The following is a description of a gene set: The chemical reactions and pathways involving isoleucine, (2R*,3R*)-2-amino-3-methylpentanoic acid. Human Gene Set: GOBP_ISOLEUCINE_METABOLIC_PROCESS species: Homo sapiens, and this is the list of marker genes: BCAT2, BCKDK, HSD17B10, ACADSB, ACAT1